The following is a description of a gene set: Human Gene Set: GOBP_SEQUESTERING_OF_CALCIUM_ION species: Homo sapiens The process of binding or confining calcium ions such that they are separated from other components of a biological system., and this is the list of marker genes: JPH1, HTT, XCL1, PRKACA, MTLN, CCL21, CXCL11, CXCL10, SLC25A23, FLNA, TGFB1, PLCB3 (NCBI Gene Id 5331), CACNA1C, CXCL9, SRI, XCR1, JPH2, PTPRC, MCOLN1, KCNK16, ERO1A, TRDN, ATP1A2, SLC8B1, CXCR3, MIR1-1, HRC, DIAPH1, PDE4D, F2R, THY1, PLCB1, LCK, LYN, PLCE1, GSTO1, GP9, CORO1A, PLCH1, FASLG, PLCG2, CASQ1, DMD (NCBI Gene Id 548327), PSEN1, ABL1, CALR, CD19, BDKRB1, MIR133A1, PLN, HTR2B, FGF2, ITPR1, TMEM38A, CAPN3, LETM1, SELENON, GSTM2, TPCN2, DRD1, TRPC1, RYR1, PLCL2, LACRT, TRPM2, CCR7, NPSR1, ANK2, GPER1, CX3CL1, CALM1, ITPR2, GP1BB, P2RX7, FKBP1A (NCBI Gene Id 2280), F2, PTK2B, IL13, DHRS7C, IBTK, APLNR, CCR5, HTR2A, PLCH2, CASQ2, RYR2, ANXA6, CCL3, PDPK1, GHITM, CALM2, BAX, UBASH3B, NTSR1, CEMIP, HAP1, TMEM38B, FKBP1B, ITPR3 (NCBI Gene Id 3710), SNCA, PLCL1, PLCG1, PRKCE, CYBA, HTR2C, P2RY6, NOL3, GP5, PTPN6, JPH3, PLCB2 (phospholipase C beta 2), GP1BA, CLIC2, ASPH, CAMK2D, DDIT3, MIR93, CCL19, CACNA1S, DRD2, CALM3, JPH4, ATP7B, LIME1, NGF, HSP90B1, PLCB4, ATG5, SLC8A1, F2RL3, CHERP, RYR3, CHD7, METTL21C, AKAP6, PKD2, ITGB3, PRKD1